Given this list of marker genes Tnr, Lamb2, Ntrk3, D130043K22Rik, Pum2, Lrp1, here is a description of the gene set: The process involved in sprouting of an injured axon. Mouse Gene Set: GOBP_SPROUTING_OF_INJURED_AXON studied in species Mus musculus